The following is a description of a gene set: species: Homo sapiens Genes up-regulated in comparison of CD25+ regulatory T cell (Treg) treated with IL4 at day 3 versus CD25- T cells incubated with IL4 at day 3. CD25+ regulatory T cells develop in the thymus (nTregs), but may also be generated in the periphery upon stimulation of naive CD4 T cells under appropriate conditions (iTregs). The mechanisms that regulate the generation of peripheral iTregs are largely unknown. We used microarrays to gain insights into the molecular program of extrathymic Treg development. Human Gene Set: GSE24634_TREG_VS_TCONV_POST_DAY3_IL4_CONVERSION_UP from publication Prots I, Skapenko A, Lipsky PE, Schulze-Koops H (PMID 21347372), and this is the list of marker genes: HSPD1, TMEM184B, PTBP1, DDX39A, EXO1, BUB3, IFRD2, RPUSD2, UBE2M, TSFM, AKAP8, RACGAP1, MAGOH, CLPP, POLR3G, MCPH1, NUP93, VARS1, TPI1, SPDL1, POLE, EIF2S1, PLK1, TWNK, GGH, ATP6V0A2, C1QBP, SLC7A5, DTL, FCER1A, PABPN1, BZW2, BORA, EXOSC2, NTHL1, ENO1, MICAL3, POP7, SPAG1, NCAPD3, TAP1, MT1G, LTB, EZR, NAA10, PMAIP1, FIBP, TTI2, PMPCA, FAM136A, LIF (LIF interleukin 6 family cytokine), TUBA3C, CDCA8, NUDCD3, CENPF, CTDNEP1, BLMH, TACC3, UBAP2 (NCBI Gene Id 57627), REXO2, POLDIP3, TARS1, MRPL24, PWP2, IPO5, HINT1, TRAF1, ILF2, CIAPIN1, BAG2 (BAG cochaperone 2), TOE1 (NCBI Gene Id 80147), GSTA4, CNPY2, NCAPH2, POLD2, MRPL58, NMT1, NCR3 (natural cytotoxicity triggering receptor 3), SNRPD3, UAP1, MRPL17 (mitochondrial ribosomal protein L17), RPS6KA5, MYBL2, MEOX1, NUDT15, CCT7, TMEM14A, TMPO, WDR43, RRM1, DCLRE1A, NOC4L, CDT1, HSPE1, TSR3, ODC1, KNTC1, TLCD3A, GINS1, UFD1, MAP4K1, BARD1, PMS1, NPRL3, NUP210, AOPEP, NUP37, DUS1L, VRK1, DTYMK, BCL2L1 (BCL2 like 1), WDR46, SFMBT1, SRM, GINS3, HNRNPM, ISG20L2, PRKD2, POLR1E, FBXO41, POLR3K, PFDN2, SUPT16H, LBHD1, MRPL23, IMP4 (IMP U3 small nucleolar ribonucleoprotein 4), CRCP, CCND2 (NCBI Gene Id 894), LONP1, CKS1B, LSM4, CCT2, EIF3I, MCAT, PRMT5, TARBP2, FUT8, PRPF8 (pre-mRNA processing factor 8), PDCD5, IFT56, PLPP1, LIG1 (NCBI Gene Id 3978, DNA ligase 1), ERCC6L, SLC43A3, PPP2R2A, TRAC, CS, ALOX5AP, SRRD, MRPS12, RCC1L, RBM28, MRE11, NVL, ATP6V0E2, IFT57, TMEM106C, NCL, HNRNPAB, C3orf52, SGTA (NCBI Gene Id 6449), BYSL, WRAP73, SNRPA1, ILKAP, MLH1, MKI67, MT1E, HAUS5, SLC25A38, CENPA, TUBB4B, GRAMD1B, RUVBL1, SS18L2, MCM10, PDCD2, CTPS1, GAPDH, ATIC, EIF2B3, CLC, KIF18A, DBF4, NOL7, BLM, NOLC1, ABHD5, DNM1L, CFAP20, RAD50, CDC45, AGO2, RBM10, MAGOHB, RNASEH2A, PNO1, NOL9, COX17, NCAPG2